The following is a description of a gene set: Human Gene Set: GSE17721_PAM3CSK4_VS_GADIQUIMOD_12H_BMDC_DN from publication Amit I, Garber M, Chevrier N, Leite AP, Donner Y, Eisenhaure T, Guttman M, Grenier JK, Li W, Zuk O, Schubert LA, Birditt B, Shay T, Goren A, Zhang X, Smith Z, Deering R, McDonald RC, Cabili M, Bernstein BE, Rinn JL, Meissner A, Root DE, Hacohen N, Regev A (PMID 19729616) mouse primary BMDCs were stimulated with tlr ligands and gene expression changes were profiled on Affymetrix arrays species: Homo sapiens Genes down-regulated in comparison of dendritic cells (DC) stimulated with Pam3Csk4 (TLR1/2 agonist) at 12 h versus DC cells stimulated with Gardiquimod (TLR7 agonist) at 12 h., and this is the list of marker genes: CMTM6, FNBP4, KRT33B (keratin 33B), PLAC8, BID, TEX12, FGG, PCDH20, RHOC, IGBP1, MYO1H, GNPTAB, CD86, CMA1, RNF2, TIMP3, SLC26A3, AGRN, ANKRD26 (NCBI Gene Id 22852), UTP6, AP5M1, RCSD1, GALNS, IFI35, GABRB2, HLA-G, HCK, C5orf52, SPSB4, CDK14, ITM2B, PTGES, BAMBI, SH3BP5, CTSK, PARP9, ZIM3, MITD1, FAP, DNAJA4, FGFR3, TLR1, CYP2F1, DHX58, ITGA4, ADAMTS5, KCNC1, EIF4ENIF1, COX18, C9orf72, TMUB2, CHMP4B, SLC6A6, DGKA, PARP14, TAMALIN, UBA7, KLF6, PSEN2, CCND2, UGDH, KLRK1, TNFRSF14, MS4A7, LMAN1L, TBC1D13, PCSK1, COL1A2, SLCO3A1, ARHGAP10, MAP4K2, PPP1R11, ARHGEF40, MYD88, SHFL, DMTN, MOV10, SNAP91, ANP32A, ATP11A, CD274, LAPTM4A, SCYL1, GLRX, LY86, CSTF3, CCNB1IP1 (cyclin B1 interacting protein 1), SNX4, PSME2, MORC3, MAGOHB, DBNL, PDCL, NUB1, EPS15L1, TBX3, YWHAH, SPG11, TNPO2, PKIG (cAMP-dependent protein kinase inhibitor gamma), SGK1, PML, P2RY14, STAT4, NFIA, ADCY6, SCN4A, KLF15, CLIP1, KTN1, RAPSN, PRPF38A, SPRYD7, PNP, WFS1, TM2D1, C8orf33, ATP8B3, ZBTB2, CHTOP, CXCL3, TIPARP, SAP30, DGUOK, TPM2 (tropomyosin 2), POLD3, TRAFD1, USP25, DGKZ, ASAH2, DBN1, BST2, NASP, SMAD4, TAB2, KBTBD4, PTMS, TRIM26, CD84, CXCL10, NR2C1, S100A8, SRPRA, PRKCE, TMEM128, CCL13, CSF3R, B4GALT5, SERPINB9, RAB22A, MPEG1, RRAGC, MAD2L2, IL7R, GSTK1, ENTR1, EPHA3, CKAP2, GBP6, IL10, EPSTI1, PROCR, FUT1, AP3M2, IGFBP5, ADGRA3, GNB4, SLC44A4, NSUN4, SLC41A1, CYTH1, IL12B, EML6, CCDC80, PSME1, BRAF, OGFRL1, CD200, ACOX2, RAP1B, PAXBP1, PGLYRP1, CCL5, IL18BP, SPOP, STXBP3, AFTPH, SPSB1 (NCBI Gene Id 80176), PAN2, TXLNG, NAMPT, TAPBP, DUSP14, IRF2, RAB20, IFI27L2, CENPM, SMNDC1, LPXN, SOCS1